Given this list of marker genes SNX17, BMPR1A, NGFR, EFEMP2, GAA, LEP, MEGF8, PRDM1, NOTCH1 (NCBI Gene Id 54781), PCDHA10, PLXND1, DLL4, NKX3-1, EGR2, TBX2, FKBP10, LRP1, HECTD1, ROBO1, SUFU, AP2B1, DCTN5, TFAP2B, PROX1 (NCBI Gene Id 5629), SIX1, HEY1, ROBO2, HEY2, PRICKLE1, EYA1, PDE2A, FOXH1, CHD7, SEC24B, NDST1, EFNB2 (NCBI Gene Id 1948), SOX4, MYLK, PDGFRB, LRP2, NPRL3, EDNRA, MYH10, NAGLU, APLNR, CNTRL (NCBI Gene Id 11064), HES1, FGF8, TBX1, TGFBR2, RBPJ (recombination signal binding protein for immunoglobulin kappa J region), FAM3D, TAB1 (NCBI Gene Id 10454), ACVRL1, MIR143, ENG, SRF, PKD2, COL3A1, LOX, MIR205, MIR145, JAG1, LOXL1, ADAMTS6, MIR29B1, SMAD6, ADAMTS9, TGFB2, here is a description of the gene set: The progression of the aorta over time, from its initial formation to the mature structure. An aorta is an artery that carries blood from the heart to other parts of the body. studied in species Homo sapiens Human Gene Set: GOBP_AORTA_DEVELOPMENT